Given this list of marker genes EPN2, NDRG1, PDLIM5, TM4SF1, SPRED2, LETM1, SDC4, PLPP3, TNFRSF1A, PCDH7, ARHGDIA, ARF6, FGF2, EHBP1L1, LRP8, SOX13, ELL2, EHD1, IL7R, THBS1, ING2, RGS2, AKAP12, PLK2, VAV2, EZR, YKT6, TOP1 (NCBI Gene Id 7150), MAT2A, TUBGCP2, CD55, DKK1, CAPRIN2 (caprin family member 2), RYK, IL11, TBX3, BCL3, SLC7A11, TXNRD1, RPS6KB2, SRPRA, THOC1 (THO complex subunit 1), TPM4, SH2B3, ARPC4, DLGAP4, SYDE1, DNMBP, FARSA, GJB3, NUP160, CDK17, SHB, GFPT2, ZEB1, GRAMD2B, RBMS1, CREM, FHL3, here is a description of the gene set: Genes whose expression peaked at 240 min after stimulation of HeLa cells with EGF. Human Gene Set: AMIT_EGF_RESPONSE_240_HELA from publication Amit I, Citri A, Shay T, Lu Y, Katz M, Zhang F, Tarcic G, Siwak D, Lahad J, Jacob-Hirsch J, Amariglio N, Vaisman N, Segal E, Rechavi G, Alon U, Mills GB, Domany E, Yarden Y (PMID 17322878) studied in species Homo sapiens Signaling pathways invoke interplays between forward signaling and feedback to drive robust cellular response. In this study, we address the dynamics of growth factor signaling through profiling of protein phosphorylation and gene expression, demonstrating the presence of a kinetically defined cluster of delayed early genes that function to attenuate the early events of growth factor signaling. Using epidermal growth factor receptor signaling as the major model system and concentrating on regulation of transcription and mRNA stability, we demonstrate that a number of genes within the delayed early gene cluster function as feedback regulators of immediate early genes. Consistent with their role in negative regulation of cell signaling, genes within this cluster are downregulated in diverse tumor types, in correlation with clinical outcome. More generally, our study proposes a mechanistic description of the cellular response to growth factors by defining architectural motifs that underlie the function of signaling networks.